Given this list of marker genes Lars2, Ccl5, Hspa1a, Fos, Hspa1b, here is a description of the gene set: from publication Cui A, Huang T, Li S, Ma A, Pérez JL, Sander C, Keskin DB, Wu CJ, Fraenkel E, Hacohen N (PMID 38057668) Cytokines mediate cell-cell communication in the immune system and represent important therapeutic targets. A myriad of studies have highlighted their central role in immune function, yet we lack a global view of the cellular responses of each immune cell type to each cytokine. To address this gap, the authors created the Immune Dictionary, a compendium of single-cell transcriptomic profiles of more than 17 immune cell types in response to each of 86 cytokines (>1,400 cytokine-cell type combinations) in mouse lymph nodes in vivo. A cytokine-centric view of the dictionary revealed that most cytokines induce highly cell-type-specific responses. For example, the inflammatory cytokine interleukin-1β induces distinct gene programmes in almost every cell type. A cell-type-centric view of the dictionary identified more than 66 cytokine-driven cellular polarization states across immune cell types, including previously uncharacterized states such as an interleukin-18-induced polyfunctional natural killer cell state. Genes negatively differentially expressed in cell type: CD8+ T cell upon treatment with cytokine: IL-17E in mouse lymph nodes in vivo. Mouse Gene Set: CUI_T_CELL_CD8_IL17E_RESPONSE_DN studied in species Mus musculus